The following is a description of a gene set: Human Gene Set: HOWLIN_CITED1_TARGETS_2_UP from publication Howlin J, McBryan J, Napoletano S, Lambe T, McArdle E, Shioda T, Martin F (PMID 16278680) Genes up-regulated in mammary glands from the CITED1 knockout mice: homozygotic vs wild type (WT) animals. Expression microarray analysis identified CITED1 among a group of genes specifically upregulated in the pubertal mouse mammary gland. At puberty, CITED1 localizes to the luminal epithelial cell population of the mammary ducts and the body cells of the terminal end buds. Generation of CITED1 gene knockout mice showed that homozygous null mutants exhibit retarded mammary ductal growth at puberty and, in addition, dilated ductal structures with a lack of spatial restriction of the subtending branches. Analysis of CITED1 homozygous null and heterozygous null mammary gland gene expression using microarrays suggested that the mammary-specific phenotype seen in the homozygous null females is due to a disturbance in the transcription of a number of key mediators of pubertal ductal morphogenesis. These include estrogen and TGFbeta responsive genes, such as the EGFR/ErbB2 ligand, amphiregulin, whose transcription we suggest is directly or indirectly regulated by CITED1. studied in species Mus musculus, and this is the list of marker genes: NFIA, RESF1, IQGAP1, TRIM27, FBXO32 (F-box protein 32), KIF18A, UCP1, WNT5A, MALAT1, SMARCA4, SGCG, XIST, GBP2, LACTB2, CD24, MAP3K7, DYNLT1, SPRR1A, MYB, IFI44